The following is a description of a gene set: Human Gene Set: HP_EPIDURAL_HEMORRHAGE Epidural hemorrhage studied in species Homo sapiens Hemorrhage occurring between the dura mater and the skull., and this is the list of marker genes: SERPINE1, FGA, FGG, FGB, F8, IPO8